Given this list of marker genes BTRC, FZR1, CDC14B, UBE2C, CDC20, UBE2S, SKP1, PLK1, here is a description of the gene set: Any process that activates or increases the frequency, rate or extent of ubiquitin protein ligase activity. studied in species Homo sapiens Human Gene Set: GOBP_POSITIVE_REGULATION_OF_UBIQUITIN_PROTEIN_LIGASE_ACTIVITY